The following is a description of a gene set: Genes positively differentially expressed in cell type: ILC (innate lymphoid cell) upon treatment with cytokine: IL-1α in mouse lymph nodes in vivo. from publication Cui A, Huang T, Li S, Ma A, Pérez JL, Sander C, Keskin DB, Wu CJ, Fraenkel E, Hacohen N (PMID 38057668) Mouse Gene Set: CUI_ILC_IL1A_RESPONSE_UP Cytokines mediate cell-cell communication in the immune system and represent important therapeutic targets. A myriad of studies have highlighted their central role in immune function, yet we lack a global view of the cellular responses of each immune cell type to each cytokine. To address this gap, the authors created the Immune Dictionary, a compendium of single-cell transcriptomic profiles of more than 17 immune cell types in response to each of 86 cytokines (>1,400 cytokine-cell type combinations) in mouse lymph nodes in vivo. A cytokine-centric view of the dictionary revealed that most cytokines induce highly cell-type-specific responses. For example, the inflammatory cytokine interleukin-1β induces distinct gene programmes in almost every cell type. A cell-type-centric view of the dictionary identified more than 66 cytokine-driven cellular polarization states across immune cell types, including previously uncharacterized states such as an interleukin-18-induced polyfunctional natural killer cell state. studied in species Mus musculus, and this is the list of marker genes: Cx3cl1, Ostf1, Stat5a, Sdc4, Batf, Stx11, Serp1, Gadd45b, Ccr7, Dap, Far1, Traf1, Srm, Dhrs3, Il4i1, Bcl2a1d, Idi1, Cd72, Atg101, Kdm6b, Psme2, Pdia6, Map3k8, Bcl2a1b, Arap2, Lad1, Gzmc, Slc15a3, Tmed5, Spcs2, Tnip3, Icosl, Derl1, Csf2, Dll1, Tnfrsf9, Sdhaf1, Dad1, Manf, Cd74, Calr